Given this list of marker genes PLK4, CEP152, DEUP1, CCDC78, CEP63 (NCBI Gene Id 80254), here is a description of the gene set: Centriole assembly in which a centriole arises de novo by a process involving an electron-dense structure known as a deuterosome, rather than by duplication of an existing centriole, and occurring as part of multi-ciliated epithelial cell differentiation. studied in species Homo sapiens Human Gene Set: GOBP_DE_NOVO_CENTRIOLE_ASSEMBLY_INVOLVED_IN_MULTI_CILIATED_EPITHELIAL_CELL_DIFFERENTIATION